Given this list of marker genes RERE, GRSF1 (G-rich RNA sequence binding factor 1), ARHGEF3, SLMAP, ARHGAP1, TMX2, RHOH, TMEM234, FCRLA, SLC37A4, COMT, NDUFB3, SASS6, KLRD1, SPIN1, GMFG, TGFB3, BAAT, MRPL24, TM2D2, GAS2, PTTG1IP, PPP3CA, TCN2, BLNK, SNAP91, STK24, COPS7A, CHMP5, PARP1, DBNL, WLS, COX6A1, GIMAP1, CSF2RA, PLG (plasminogen), GRK5, CXorf38, LDHC, IMMP1L, RRAS, SEMA4B, GYG1, SLC25A11, ORMDL3, TTC3, ACAA1, COPS7B, PNPT1, TRIM41, KLHL7, TMEM179B, VPS54, PITPNA, MBD4, ANKRD17, ATP5MK, ASH1L (ASH1 like histone lysine methyltransferase), PGM2, RAB12, POLR2J, ABCB1, CERS2, RNF181, RNPEPL1, ARPC2, FN1, NAV1, CDC42SE2, NGRN, GGT1, MINDY1, PTPN12, PIGA, SYS1, RAC2 (Rac family small GTPase 2), LEPR, CAMLG, CCR5, UBLCP1, DDHD2, CFH, ZSWIM1, RASA3, LTBP2, PARP2, HBE1, AKR1E2 (NCBI Gene Id 83592), FAAP20, AP4S1, PTPN21, DNAAF5, LY6E, SRSF3, ANKRD28, PTPRO, B3GALT2, CD200 (CD200 molecule), GTF3C1, GK, SYPL1, TAX1BP1, POU2F1, MIP, RBX1, EXOSC4, AVIL, RHOQ, PDCD6, TNFRSF21, ARHGAP21, MGAT1, TUBGCP3, FLT3LG, NIPSNAP2, LCP1, SOWAHC, HELB, METTL18, DUSP8, PHLDA1, NAT1, SHKBP1, ZFP1, CETN2, PCMT1, TOPBP1, PDE6D, NXF1, RAB28, CNPY2, TTC14, KRTAP12-2, ITM2A, S100A6, PLXNA2, SGF29, ASH2L, FAHD1, GZMA, FCGR2B, ACTR6, PLXNB2, HERC2, EBF1, TMEM106C, FANCM, COX6B2, CAST, CPQ, DUSP6, CPSF3, GBX2, TM9SF2, CCDC186, ZNF274, RSRP1, ZNF347, FXYD5, ARID1A, PSMD1, ITGB2, ZNF740, REEP5, RNGTT, AHNAK, EMB, ARHGAP35, DKK2, PITPNC1, HS3ST1, LPCAT3, ETFBKMT, PIAS3, COPB2, C1QL1, ETAA1, PTGER3, MAD2L1BP, TM9SF3, NONO, S100A11, MORC4, AKIRIN2, ADPRM (ADP-ribose/CDP-alcohol diphosphatase, manganese dependent), RABGAP1L, SRP9, ITSN1, TMED4, POLG, HSDL2, DDOST, AP3S2, DPM1, CCNG2, EIF2AK3, TMEM167A, MAIP1, MARCHF6, MIOS, here is a description of the gene set: studied in species Homo sapiens Human Gene Set: GSE46143_CTRL_VS_LMP2A_TRANSDUCED_CD10_POS_GC_BCELL_DN from publication Vockerodt M, Wei W, Nagy E, Prouzova Z, Schrader A, Kube D, Rowe M, Woodman CB, Murray PG (PMID 23592216) Genes down-regulated in MME+ germinal center B lymphocytes: control versus over-expressing viral (EBV) gene LMP2A. In this study, we have investigated the effect of LMP2A on gene expression in normal human GC B cells using a non-viral vector based system